The following is a description of a gene set: electronically inferred by orthology from the curated human pathway species: Mus musculus Reactome Pathway: Interleukin-12 signaling part of: Interleukin-12 family signaling This event has been computationally inferred from an event that has been demonstrated in another species.<p>The inference is based on the homology mapping from PANTHER. Briefly, reactions for which all involved PhysicalEntities (in input, output and catalyst) have a mapped orthologue/paralogue (for complexes at least 75% of components must have a mapping) are inferred to the other species., and this is the list of marker genes: Tyk2, Il12a, Il12b, Stat4, P4hb